The following is a description of a gene set: The regression phase of the hair cycle during which cell proliferation ceases, the hair follicle shortens, and an anchored club hair is produced. species: Mus musculus Mouse Gene Set: GOBP_CATAGEN, and this is the list of marker genes: Tgfb2, Gal, Ctsl, Trpv1, Cdh3, Gsdma3, Barx2, Msx2